The following is a description of a gene set: An abnormality of the epididymis. Human Gene Set: HP_ABNORMAL_EPIDIDYMIS_MORPHOLOGY Abnormal epididymis morphology studied in species Homo sapiens, and this is the list of marker genes: MEFV, IL12A, IGHG2, LYN, SRCAP, BTK, HLA-B, PIK3CA, UNG, CLDN2, TLR4, HNF1B, CREBBP, IL23R, IL10, FAS, CCR1, ERAP1, UBAC2, DHH, PSMB8, IL12A-AS1, IFNGR1, KLRC4, C4A, STAT4, VHL, CCND1, IGKC, EP300 (E1A binding protein p300)